The following is a description of a gene set: species: Mus musculus Mouse Gene Set: GOBP_REGULATION_OF_EPITHELIAL_TO_MESENCHYMAL_TRANSITION Any process that modulates the rate, frequency, or extent of epithelial to mesenchymal transition. Epithelial to mesenchymal transition where an epithelial cell loses apical/basolateral polarity, severs intercellular adhesive junctions, degrades basement membrane components and becomes a migratory mesenchymal cell., and this is the list of marker genes: Sdcbp, Spred3, Bmpr1a, Grem1, Lrg1, Aplf, Dact3 (dishevelled-binding antagonist of beta-catenin 3), Mcrip1, Bambi, Tgfbr2, Dag1, Tgfb2, Tgfb3, Mtor (NCBI Gene Id 80612), Zfp750, Il6, Phldb1, Ezh2, Smad7, Bcl9l, Isl1, Tgfbr3, Alx1 (NCBI Gene Id 216285), Acvr1, Sfrp2, Tsc2, Il1b, Ctnnb1, Eng, Pten, Hpn, Gata3, Sdhaf2, Kdm1a, Ppp2ca, Dab2, Kat8, Pdpn, Notch1, Tgfb1i1, Tiam1, Spred1, Myocd, Usf3, Tbx20, Gsk3b, Loxl2, Foxa2, Pawr, Phldb2, Spry2, Fbxo11, Ptk2, Smad3, Foxc1, Crb2, Agt, Gcnt2, Nog, Ldlrad4, Spsb3, Col1a1, Snai1, Smad2, Tgfbr1, Glipr2, Trim62, Epha3, Adam8, Nkx2-1, Qki, Mdk, Spred2, Olfm1, Twist1, Efna1 (ephrin A1), Sfrp1, Dsg2, Tgfb1, Mad2l2, Ager, Epha4, Wwtr1, Fuz, Clasp2, Fermt2 (fermitin family member 2), Jag1 (jagged 1), Axin2, Il17rd (interleukin 17 receptor D), Foxa1, Pofut2, Clasp1, Adipor1, Smad4, Emp2, Zfp703 (zinc finger protein 703), Bmp7, Ell3 (elongation factor RNA polymerase II-like 3), Mark1, Vasn, Tcf7l2, Bmp2, Lef1, Dab2ip, Rgcc, Ovol2, Bmp4, Hdac2, Spry1, Vegfa